The following is a description of a gene set: Conical tooth species: Homo sapiens An abnormal conical form of the teeth, that is, a tooth whose sides converge or taper together incisally. Human Gene Set: HP_CONICAL_TOOTH, and this is the list of marker genes: TSPEAR, DYNC2LI1, SUMO1, MSX1, EDAR, B3GLCT, PRKACA, ARHGEF38, ST14, FGFR1, DLX4, ATP6V0A2, KAT6A, RHOA, FGFR2, RIC1, CDH1, NEK1, PAX9, AXIN2, ATP6V1B2, ATR, PRKACB, EVC2, FGFR3, CCBE1, EVC, BMP4, RUSC2, IKBKG, NECTIN4, TGFA, COBLL1, ARID1B, ARHGAP29, TP63, DLG1, WNT10B, NECTIN1, EDARADD, GLI1, IRF6, DHODH, NAA80, LRP6, PDGFRA, WNT10A (NCBI Gene Id 93651), ALX4, FGF3, ANAPC1, EDA (ectodysplasin A), SATB2, CTNND1, RPS6KA3, SMARCD2, NFKBIA